Given this list of marker genes Nlrp5, Hsp90ab1, Faf1, Scaper, Tcl1, Prkca, here is a description of the gene set: studied in species Mus musculus Mouse Gene Set: GOCC_OOPLASM The cytoplasm of an ovum.